The following is a description of a gene set: This event has been computationally inferred from an event that has been demonstrated in another species.<p>The inference is based on the homology mapping from PANTHER. Briefly, reactions for which all involved PhysicalEntities (in input, output and catalyst) have a mapped orthologue/paralogue (for complexes at least 75% of components must have a mapping) are inferred to the other species. Reactome Pathway: Telomere C-strand (Lagging Strand) Synthesis electronically inferred by orthology from the curated human pathway part of: Extension of Telomeres species: Mus musculus, and this is the list of marker genes: Dna2, Pold1, Terf2, Prim1, Chtf18, Wrn, Lig1, Rfc3, Terf1, Pold2, Chtf8, Ten1, Ctc1, Acd, Rfc1, Rpa1, Pold4, Pola2, Pcna, Dscc1, Blm, Pola1